The following is a description of a gene set: Mouse Gene Set: REACTOME_METABOLISM_OF_POLYAMINES studied in species Mus musculus Metabolism of polyamines, and this is the list of marker genes: Psma3, Psma2, Psma1, Psmd6, Psmb3, Psmb6, Psmc6, Psmd13, Psmb5 (NCBI Gene Id 19173), Psmc5 (NCBI Gene Id 19184), Sat1, Psmb1, Oaz1, Amd1, Psma7, Psma5, Psmd2, Psmc2 (proteasome (prosome, macropain) 26S subunit, ATPase 2), Psma6, Agmat, Psmc1, Psmd11, Psmd8, Psmb2, Odc1, Psmb7, Azin1, Psma4, Psmd14, Psmb4, Srm, Nqo1, Psmd3, Oaz3, Psmd7, Oaz2, Sms, Psmc3, Adrm1, Psmd1, Smox, Azin2, Psmc4, Paox, Psmd12